The following is a description of a gene set: Nephrogenesis studied in species Homo sapiens Human Gene Set: WP_NEPHROGENESIS, and this is the list of marker genes: OSR1, TCF21, WNT3A, FOXD1, FGF20, PAX2, ALDH1A2, NOTCH2, RSPO3, MEIS1, BMP7, FGF8, WNT4, GREB1L, SIX2, WNT9B, JAG1, RSPO1